The following is a description of a gene set: studied in species Mus musculus Catalysis of the reaction: procollagen L-proline + 2-oxoglutarate + O2 = procollagen trans-hydroxy-L-proline + succinate + CO2. Mouse Gene Set: GOMF_PROCOLLAGEN_PROLINE_DIOXYGENASE_ACTIVITY, and this is the list of marker genes: P4hb, P3h2, P4ha2, P4htm, P3h1, P4ha1, P4ha3, P3h3